The following is a description of a gene set: species: Homo sapiens Human Gene Set: chr4p11, and this is the list of marker genes: TEC, MTCO3P39, MTND3P22, MTCO3P42, OCIAD1 (NCBI Gene Id 54940), SNX18P23 (sorting nexin 18 pseudogene 23), ENSG00000309878, SNX18P24, OCIAD1-AS1, ZAR1, RNU5E-3P, SLAIN2, FRYL, SLC10A4, RNU6-158P, ANKRD20A17P, SNX18P25 (sorting nexin 18 pseudogene 25), OCIAD2, CWH43, TPI1P4 (NCBI Gene Id 731573)